The following is a description of a gene set: species: Homo sapiens Pathway Definition from KEGG: Eae -> Tir -> (IRTKS,IRSp53) -> TccP -> WASL -> ARP2/3 -> (ACTB,ACTG1) Human Gene Set: KEGG_MEDICUS_PATHOGEN_ESCHERICHIA_EAE_TIR_TCCP_TO_ACTIN_SIGNALING_PATHWAY Escherichia Eae/Tir/TccP to Actin signaling pathway. Pathway ID: N01094. Pathway type: Pathogen. Pathway class: nt06135 Cytoskeletal regulation (viruses and bacteria)., and this is the list of marker genes: ARPC4 (NCBI Gene Id 10093), ARPC5L, ACTR3, ARPC2, ARPC3, ACTG1, BAIAP2, WASL (WASP like actin nucleation promoting factor), ARPC1B (actin related protein 2/3 complex subunit 1B), ARPC5, BAIAP2L1, ACTB (NCBI Gene Id 60), ACTR2, ARPC1A